Given this list of marker genes NOS1, BCL2, CALCA, EPO, TMBIM6, here is a description of the gene set: studied in species Homo sapiens Human Gene Set: GOBP_NEGATIVE_REGULATION_OF_CALCIUM_ION_TRANSPORT_INTO_CYTOSOL Any process that decreases the rate of the directed movement of calcium ions into the cytosol of a cell. The cytosol is that part of the cytoplasm that does not contain membranous or particulate subcellular components.